Given this list of marker genes Nbn, Mre11a, Rad50, Atm, Kat5, Kpna2rt, Kpna2, here is a description of the gene set: species: Mus musculus Sensing of DNA Double Strand Breaks Mouse Gene Set: REACTOME_SENSING_OF_DNA_DOUBLE_STRAND_BREAKS